Given this list of marker genes PDIA3, TOP3A, CDKN1C, CDH1, HRAS, CDK11B, CDH13, INS, ANKRD11, CTSB, FANCA, PRKCZ, LLGL1, here is a description of the gene set: Human Gene Set: CHIN_BREAST_CANCER_COPY_NUMBER_DN We analysed 148 primary breast cancers using BAC-arrays containing 287 clones representing cancer-related gene/loci to obtain genomic molecular portraits. Gains were detected in 136 tumors (91.9%) and losses in 123 tumors (83.1%). Eight tumors (5.4%) did not have any genomic aberrations in the 281 clones analysed. Common (more than 15% of the samples) gains were observed at 8q11-qtel, 1q21-qtel, 17q11-q12 and 11q13, whereas common losses were observed at 16q12-qtel, 11ptel-p15.5, 1p36-ptel, 17p11.2-p12 and 8ptel-p22. Patients with tumors registering either less than 5% (median value) or less than 11% (third quartile) total copy number changes had a better overall survival (log-rank test: P=0.0417 and P=0.0375, respectively). Unsupervised hierarchical clustering based on copy number changes identified four clusters. Women with tumors from the cluster with amplification of three regions containing known breast oncogenes (11q13, 17q12 and 20q13) had a worse prognosis. The good prognosis group (Nottingham Prognostic Index (NPI) <or=3.4) tumors had frequent loss of 16q24-qtel. Genes significantly associated with estrogen receptor (ER), Grade and NPI were used to build k-nearest neighbor (KNN) classifiers that predicted ER, Grade and NPI status in the test set with an average misclassification rate of 24.7, 25.7 and 35.7%, respectively. These data raise the prospect of generating a molecular taxonomy of breast cancer based on copy number profiling using tumor DNA, which may be more generally applicable than expression microarray analysis. Genes from common regions of losses observed in more than 15% of 148 primary breast cancer tumors. species: Homo sapiens from publication Chin SF, Wang Y, Thorne NP, Teschendorff AE, Pinder SE, Vias M, Naderi A, Roberts I, Barbosa-Morais NL, Garcia MJ, Iyer NG, Kranjac T, Robertson JF, Aparicio S, Tavaré S, Ellis I, Brenton JD, Caldas C (PMID 17001317)